The following is a description of a gene set: Mouse Gene Set: GOBP_GLOMERULAR_MESANGIUM_DEVELOPMENT The process whose specific outcome is the progression of the glomerular mesangium over time, from its formation to the mature structure. The glomerular mesangium is the thin membrane connective tissue composed of mesangial cells, which helps to support the capillary loops in a renal glomerulus. species: Mus musculus, and this is the list of marker genes: Cd34, Itgb3, Il6ra, Acta2, Bmp4 (bone morphogenetic protein 4), Pdgfa, Ifng, Egr1, Pdgfrb, C3ar1, Bmp7, Foxc2, Notch1, Cflar, Pdgfb, Pdgfd (NCBI Gene Id 71785), Serpinb7, Gpr4, Wt1